Given this list of marker genes FGF4, HGF, PIK3CA, FGF1, MAPK1, FGFR2, PLAU, NCAM1, PLCG1, CDH1, PTPN11, GRB2, SDC2, PIK3R1, CBL, STAT5B, SRC, FGF9, FGFR1, FGF19 (fibroblast growth factor 19), FGF8, SPRY2, KLB, JUN, GAB1, FGF18, BGLAP, FGF23, IL17RD, FGF17, CAMK2A, STAT1, FRS2, FGFR3, MMP9, CTNND1, PAK4, FGF2, SOS1, PTK2B, FGFR4, SPP1, SSH1, MET, RUNX2, MAPK3 (NCBI Gene Id 5595), SHC1, RPS6KA1, PDPK1, CTTN, PLAUR, FGF6, FOS, CDH2, AKT1, here is a description of the gene set: studied in species Homo sapiens from publication Schaefer CF, Anthony K, Krupa S, Buchoff J, Day M, Hannay T, Buetow KH (PMID 18832364) FGF signaling pathway Human Gene Set: PID_FGF_PATHWAY